Given this list of marker genes CPTP, FAM193A, ZNF518A, NSD2, ANKRD49, SHISA5, AKR7A3, NDUFC2, ACRV1, TAF12, TMEM25, DLG5, ALKBH8, HERC4, ANKRD28, IKZF5, CENPS, FABP3, PPP2R2D, FAM149B1, IPP, MKNK1, TRAPPC3, EMC1, MARCHF5, KIFBP, EMSY, ALG8 (ALG8 alpha-1,3-glucosyltransferase), MRPL20-AS1, TBC1D12, EIF4EBP2, SZT2, SDF4, ZC3H12C, ACTR1A, ZMYM1, GPN2, MARCKSL1, GNL3, C1orf122, GPAM (NCBI Gene Id 57678), TMEM222, RAB6A, HMGCL, MKRN2, CCSER2, RLF, ARHGEF10L, MRFAP1L1, ZBTB8B, NHLRC2, VAMP3, STT3A, LCOR, PEX14, RBM6, PBLD, NMNAT1, MACROH2A2, PIGG, ZYG11B (NCBI Gene Id 79699), RPS25, DNAJC11, KAT6B, AMOTL1, SEC24C, DNAI4, TMEM115, SEPSECS-AS1, DYNC2H1, ARIH2, CCDC174, TAF5, SCP2, MATN1-AS1, RSRP1, MLH1, RPP30, ZBTB8OS, P3H1, MMACHC, ZKSCAN7, JAGN1, SEC23IP, TM9SF3, CC2D2A, MRE11, RAB30-DT, CDON, SETD2, HYI, RIMS3, TMEM126B, BTD, HIF1AN, NME6, TRIM62, DDI2, PUS3, PPP3CB, KIF11, EIF1B, DNAJC9, RNF19B, PINK1 (PTEN induced kinase 1), PER3, ZBTB17, OXSR1, SH3GLB1, RNF4, FCHSD2, HECTD2, LRRC41, FOXRED1, ALG9, CLIC4, NEK4, SELENON, ADD3, CCDC28B, RNF11, ECHS1, FPGT, FGD5, ARHGEF12, ZBTB48, CYTL1, ELOVL1, RNF169, TXLNA (taxilin alpha), ACAD8, DDX50, NELFA, FAM168A, PNRC2, PTEN, THUMPD3, MRFAP1, JAM3, WRAP73, SNX19, NRBF2, TMEM175, C11orf54, MKI67, SCAP, RNF220, CENATAC, GPR153, DALRD3, ZDHHC18, TRUB1, SH3BGRL3, CMPK1, CHST15, RDX, LRRC47, RUFY2, NCAPG, SF3A3, LZIC, LEPR (leptin receptor), FHIP2A, LCK, H6PD, PICALM, ICMT, CLCN6, CEP57, C2CD3, NEAT1, SMARCC1 (SWI/SNF related, matrix associated, actin dependent regulator of chromatin subfamily c member 1), STK40, HECTD3, PCGF3, RAB5A, JUN, CUTC, WDR11, TACC3, CTBP2, PCGF6, HSPA8, PANX1, NKTR, CAPZB, PODN, DCAF1, NOP14, TNFRSF1B, TRNAU1AP, SYNC, BLOC1S4, UGDH, MIB2, SLBP, STT3B, POLR3A, LYAR, FBXW4, CLSTN1, BMPR1A, POLD3, MIGA1, EDRF1, RBM15B, MINPP1, LTO1, RUNX3, METTL6, NASP, KDM4D, ARHGAP32, FANCD2, PHC2, BEND4, ATPAF1, NR2C2, PRDX3, BUB3, KHDRBS1, SLAIN2, IFT25, CD52, NFIA (nuclear factor I A), CASP9, ZBTB8A (NCBI Gene Id 730411), ZNF502, COL9A2, PTP4A2, IFT46, CACUL1, WDTC1, FADS3, ELOA-AS1, LYPLA2, MICU1, FNDC5, UBIAD1, NCDN, DNAJC16, MED17, THAP12, AP3M1, ANAPC16, LRRC42, MYRIP (myosin VIIA and Rab interacting protein), GLT8D1, UBE4A, GLB1L2, EPHA10, PLEKHM2, ANAPC15, STX12, ZFYVE27, PTBP2, ATG7, DHX15, DENND10P1, NUMA1, TENM4, HP1BP3 (heterochromatin protein 1 binding protein 3), SS18L2, ZNF621, C1orf52, BCO2, TMEM135, ECE1, CNOT10, UBP1, GRPEL1, NRDC, FBLIM1 (NCBI Gene Id 54751), HNRNPR, TARDBP, PPME1, GHITM, RNF26, NOL9, USP33, FBXO6, ZSWIM8, SVBP, VPS13D, SLC66A1, SLC37A4, KIAA0319L, INTS11, RAD18 (NCBI Gene Id 56852), SH3BP2, ATP5MG, TADA3, PTS (6-pyruvoyltetrahydropterin synthase), RNF214, RPA2, SMIM38, ZRANB2 (NCBI Gene Id 9406), LEPROT, MIIP, EED, SLC30A9, CEP104, DFFB, ZNF445, TTLL7, CAPN7, CAP1, NAT8L, LRTOMT, TAF1D, MAN1C1, ZNF684, CTDSPL, ARL8B, DPAGT1, HIKESHI, RBM7, DOCK7, THUMPD3-AS1, C1orf50, SLC25A34, SC5D, CAMK2G, ZMYM4, TPRG1L, DHX30, SFPQ, CTNNBIP1, CCNL2, MED8, EIF4G3, PAAF1, CWF19L2, FAM76B, MED28, ATM, NSUN4, YTHDF2, HAUS3, MAST2, USP4, IFIT5, MFSD10, PUM1, PIGK, CHDH, ECD, SPATA6, HYAL2 (NCBI Gene Id 8692), LINC01128, BCL10, INTS4, ARHGEF17, ASAP3, RSF1, ATG16L2, CHORDC1, THYN1, AGO3, SPCS2, ST3GAL3, PSTK, FRAT2, PPT1, SMAP2, PIK3R3, TRAK1, NECAP2, EEF1AKMT2, RHOA, DNAJC6, NPAT, RER1, EXOSC10, TMEM218, AHDC1, AKIRIN1, CHL1, C11orf71, RBPJ, QRICH1, ZNF436-AS1, KIF15, UBR4, PAK1, PLEKHA1, UBE2E1, RPUSD4, EBNA1BP2, CEP85, CPEB2, KRBOX1, NGLY1, EPB41, RPL15, TXNDC12, TAF6L, TNFRSF25, CZIB, MAEA, AGO4, CNTN4, ATP13A2 (ATPase cation transporting 13A2), NADK, HK1, DCUN1D5, APLP2, TLCD5, KDM4A, MYCL, TBC1D1, MORN4, ADPRS, GAK, HNRNPH3, TTC39A, TOP2B, PGAM1, SIRT1, LSM10, CTNNB1, COL16A1, LIMD1 (NCBI Gene Id 8994), CPEB3, PRKCZ, NAALAD2, GRIA4, ADGRB2, TUSC2, PHF13, ARMH3, WDR6, FAM76A, PIGV, MTHFR, MICOS10, MRPS25, DGAT2, NKAPD1, LETM1, ATRIP, DPF2, SHISA3 (NCBI Gene Id 152573), CUL5, RBSN, EPS15, TMEM201, BSDC1, STAMBPL1, THAP3, TMEM39B, ACAT1, ARL3, GNB1, DMAP1, SEC22C, ARHGAP1, STMN1, ELAVL4, WNT4, ABRAXAS2, NHSL3, MANEAL, BMP8B, GLUD1, SETD5, ZMPSTE24, PEF1, CRMP1, ZNF436, RPS6KA1, PHACTR4, SORBS1, RPSAP20, C1QB, ZMYND12, MEAF6, CAMTA1, MTMR2, LSM3, CCDC82, ANKRD13C, SH3PXD2A, MTG1, TBCEL, LUZP1, DCAF16, ELP6, ZPR1, TKT, BTF3L4, SMIM20, NUP210, RAF1, PDCD4, CHD5, CDC25A, ZNF589, FRAT1, MUL1, NFRKB (nuclear factor related to kappaB binding protein), CEP295, PLAAT3, PI4K2A (phosphatidylinositol 4-kinase type 2 alpha), CCDC85B (coiled-coil domain containing 85B), CYP2E1, STIMATE, C10orf88, CRBN, LDB3 (NCBI Gene Id 1219), BACE1-AS, SETMAR, APEH, NCAPD3, PAFAH2, TMEM51, PCBD1, AKR7A2, UVSSA, ENSG00000238142, SSX2IP, RGS12, USP28, EVA1B, IL17RD, BTBD19, HEYL, JAKMIP3, SNRNP40, CDC42, ODF2L, PARK7, FBXO42, SLC9A1, GPBP1L1 (NCBI Gene Id 60313), THEMIS2, EPM2AIP1, YIPF1, CLASP2, CTBP1, ZSWIM5, EEF1G, GBF1, VGLL4 (NCBI Gene Id 9686), SYT7, GALE, PPP1CA, S100PBP, CCDC12, RAB11FIP2, ABCG4, BORCS7 (NCBI Gene Id 119032), ERI3, LARS2, CLPB, ZCCHC17, BAP1, ASRGL1, BBIP1, ATXN7, TMEM50A, FAF1, CPLX1, SIDT2, PRKAR2A, ASCC1, TEX264, SRSF11, HPCAL4, TMEM123, TMEM59, DPYSL4, ZMYM6, SRSF8, FOXJ3, ZBTB44, DDX21, CMTM6, EXO5, RCAN3, PCF11, SLC35E2B, ATE1, VTI1A, R3HCC1L, ATP6V0B, PRDM10, PRPF38A, CBL, TMEM35B, GOLGA7B (NCBI Gene Id 414267), PACRGL, CFAP68, MOB3C, ARRB1, NUDC, ATRNL1, CHCHD1, LAP3 (leucine aminopeptidase 3), PRKACB, DHDDS, JRKL, TM2D1, SRSF4, QARS1, EFCAB7, PCGF3-AS1, ACOT7, SLC4A7, UVRAG (UV radiation resistance associated), NKAIN1, UBE2J2, BOD1L1, ATP5ME, RRAGC, SGPL1, DDX10, XPNPEP1, TRIM8, ME3, ZNF202, SPEN, MYSM1, LAMTOR1, ZNF362, LRRC40, MRPS16, ACVR2B, FDXACB1, SZRD1, MAP7D1, MRPL43 (NCBI Gene Id 84545), AVPI1, MSANTD4, PAQR7, ATP5MK, EXOC6, MTFR1L, SMIM12, PPIE, PPCS, SRRM1, PRXL2A, H2AX, VHL, FBXL15, PDZD8, B3GALT6, KMT2A, DNAJC8, TMEM234, FUT11, BEND5, CHEK1, DDOST, GFOD3P, RELL1, GOLGA4, VPS26A, PTGFR (NCBI Gene Id 5737), FRYL, KCNAB2, UTP11, PTAFR, GVQW3, SDHB, JAK1 (NCBI Gene Id 3716), KIAA2013, IQSEC1, ANKRD42-DT, SCMH1, HINFP, KIAA1143, NUDT13, DNALI1, ADGRA3, BIRC2, INPP5F, TBC1D5, SATB1, DLAT, ZNF721, WAPL, EFCAB14, RHCE, PPP1R8, RBMS3, HIVEP3, COA4, FEZ1, SNIP1, RBBP4, CMTM8 (CKLF like MARVEL transmembrane domain containing 8), DYNC1LI1, SLC35F2, BTAF1, HPS6, TBRG1 (transforming growth factor beta regulator 1), TMEM43, EFHD2, SESN2, AZI2, CLNS1A, GRID1, NDUFAF3 (NCBI Gene Id 375340), IPO13, NBPF3, INPP5A (inositol polyphosphate-5-phosphatase A), OGG1, MTOR, HYOU1, ELOA, GLB1L3, BAD, TUBGCP2, NDST2, PDCD6IP, RPL32, FGFBP3, SHOC2, USP48, PRXL2B, BTRC, TBC1D14, CCDC186 (NCBI Gene Id 55088), FGR (FGR proto-oncogene, Src family tyrosine kinase), AS3MT, IMPDH2, HYLS1, MACF1, CREBZF, MFN2, MRFAP1L2, BUD13 (BUD13 homolog), ATAD1, MIER1, MIR100HG, REEP3, MSANTD2, UBE4B, CWF19L1, FDX1, PBRM1, MTF1 (NCBI Gene Id 4520), FTH1, GPATCH3, PANK4, NDUFB8, TSKU, MTMR14, VPS26B, NARS2, SDHD, DNAJB12, C1orf216, SIK3, LDLRAP1, CUEDC2, ZMIZ1, LRRN1, HMBS, ZRANB1, TATDN2, RERE, TIMM8B, SSU72, RAB30, UROD, PITHD1, FUT4, KPNA6, TNKS2, RAB3B, PTPRF, POMGNT1, OSBPL9, OAT, AK2, THRAP3, MAD2L2, TUT4 (terminal uridylyl transferase 4), HPDL (NCBI Gene Id 84842), ARCN1, CROCCP2, TMA7, PGM1, SPSB1, MED18, INA, TMEM126A, LAPTM5, PRDM2, AASDHPPT, KIF1B, DNAJC9-AS1, RPS3, CCDC66, FYCO1, CWC15, COX15, ARID1A, MRPL48, WDR48 (WD repeat domain 48), PGM2, AFAP1, here is a description of the gene set: Human Gene Set: LASTOWSKA_NEUROBLASTOMA_COPY_NUMBER_DN species: Homo sapiens Genes with copy number losses in primary neuroblastoma tumors. Identifying genes, whose expression is consistently altered by chromosomal gains or losses, is an important step in defining genes of biological relevance in a wide variety of tumour types. However, additional criteria are needed to discriminate further among the large number of candidate genes identified. This is particularly true for neuroblastoma, where multiple genomic copy number changes of proven prognostic value exist. We have used Affymetrix microarrays and a combination of fluorescent in situ hybridization and single nucleotide polymorphism (SNP) microarrays to establish expression profiles and delineate copy number alterations in 30 primary neuroblastomas. Correlation of microarray data with patient survival and analysis of expression within rodent neuroblastoma cell lines were then used to define further genes likely to be involved in the disease process. Using this approach, we identify >genes within eight recurrent genomic alterations (loss of 1p, 3p, 4p, 10q and 11q, 2p gain, 17q gain, and the MYCN amplicon) whose expression is consistently altered by copy number change. Of these, 84 correlate with patient survival, with the minimal regions of 17q gain and 4p loss being enriched significantly for such genes. These include genes involved in RNA and DNA metabolism, and apoptosis. Orthologues of all but one of these genes on 17q are overexpressed in rodent neuroblastoma cell lines. A significant excess of SNPs whose copy number correlates with survival is also observed on proximal 4p in stage 4 tumours, and we find that deletion of 4p is associated with improved outcome in an extended cohort of tumours. These results define the major impact of genomic copy number alterations upon transcription within neuroblastoma, and highlight genes on distal 17q and proximal 4p for downstream analyses. They also suggest that integration of discriminators, such as survival and comparative gene expression, with microarray data may be useful in the identification of critical genes within regions of loss or gain in many human cancers. from publication Łastowska M, Viprey V, Santibanez-Koref M, Wappler I, Peters H, Cullinane C, Roberts P, Hall AG, Tweddle DA, Pearson AD, Lewis I, Burchill SA, Jackson MS (PMID 17533364)